Given this list of marker genes Uimc1, Rnf168, Sirt1, Sirt6, Kat5, Aplf, Hdac3, Dtx3l (deltex 3-like, E3 ubiquitin ligase), Parp2 (NCBI Gene Id 30876), Trip12, Kdm1a, Brcc3dc, Hpf1, Asf1a, Sirt7, Babam1, Hdgfl2 (NCBI Gene Id 15193), Ubr5, Apbb1, Phf1, Usp3, Usp51, Rnf8, Brcc3 (BRCA1/BRCA2-containing complex, subunit 3), here is a description of the gene set: Mouse Gene Set: GOBP_DNA_REPAIR_DEPENDENT_CHROMATIN_REMODELING A chromatin remodeling process that allows DNA repair enzyme to access genomic DNA and repair DNA lesions. species: Mus musculus